The following is a description of a gene set: Human Gene Set: GOMF_INTERLEUKIN_17_RECEPTOR_ACTIVITY species: Homo sapiens Combining with any member of the interleukin-17 family of cytokines and transmitting the signal from one side of the membrane to the other to initiate a change in cell activity., and this is the list of marker genes: IL17RA, IL27RA, IL17RC (interleukin 17 receptor C), IL17REL (interleukin 17 receptor E like), IL17RB, IL17RD, IL6ST, IL17RE